Given this list of marker genes ARSA, CACNA1A, MKS1, BAP1, CREBBP, BPTF, LEPR, USP48, HDAC8, TWNK, PSMD12, VAPB, ARMC5, SOD1, HLA-DQB1, CEP19, SATB2, CHMP2B, PIK3CA, TNIK, ERBB4, HNRNPA1, SMO, SRPK3, LAS1L, PDCD6IP, SUFU, ATRX, ATP1A2, SNORD118, B4GALNT1, TP53, POLG, IFT172, CLCNKA, SCAPER, IFT74, SLC39A4, CASR, RNF168, GRIN2A, OPTN, PDGFB, SLC1A3 (solute carrier family 1 member 3), GLE1, EP300, TBK1, PLA2G6, PSAP, BBS1, TUBB3 (tubulin beta 3 class III), SRPX2, TDO2, SCLT1, BSND, PPARGC1A, UBQLN2, GNAS, FMO3, CEP290, PGK1, PRNP, NAGS, NOTCH3, C19orf12, PON1, CCNF, MIR17HG, TRIM32, SDCCAG8, NEFH (neurofilament heavy chain), CLTRN, CFAP418, USP8, TTC8, NEK1, GNA11, UNC13A, BBS5, TRAF7 (TNF receptor associated factor 7), DAO, DGCR6, EIF2B1, TERT, FUS, MATR3, WDPCP, MTPAP, SARDH, DGCR8, CFAP410, NHLRC1, MED12, CDH23, KDM1A, FIG4, SPART, CHCHD10, PDE11A, PRKACA, PFN1, PON2, SQSTM1 (NCBI Gene Id 94002), ARL6, SLC6A19, HTRA1 (NCBI Gene Id 5654), ANG, GALC, MAPK8IP3, TBX1, CUL4B, TAF15, PON3, GABRG2, ESS2, CTSF, ATXN2, PRPH, BBS12, BBS9, EPM2A, SMARCE1, BBS7, NF2, ZFYVE26, VPS13A, RNF125, AIP, BBS2, BBS10, ANXA11, BBIP1, NPHP1, AKT1, PRKAR1A, TREM2, SLC6A17, SPG11, BBS4, MECP2, DDC, LZTFL1, MKKS, TARDBP, IFT27, RFX7, BCS1L, ELP1, ATP1A3, VCP, NR3C1, PANK2, CLCNKB, DGCR2, DCTN1, BRAF, NTRK1, GLT8D1, SMARCB1 (SWI/SNF related, matrix associated, actin dependent regulator of chromatin, subfamily b, member 1), GRIK2 (glutamate ionotropic receptor kainate type subunit 2), HLA-DRB1, DEAF1, FTL, SPTBN1, here is a description of the gene set: Emotional lability Unstable emotional experiences and frequent mood changes; emotions that are easily aroused, intense, and/or disproportionate to events and circumstances. species: Homo sapiens Human Gene Set: HP_EMOTIONAL_LABILITY